The following is a description of a gene set: A general defect of GF K/BxN T cell proliferation response toward antigen motivated us to look for the impairment in GF K/BxN T cells that might leads to the low Ab production and reduced disease phenotype seen in GF K/BxN mice. To find the difference between GF and SPF K/BxN T cells in a broad and non-biased fashion, we performed gene-expression profiling of these cells using microarrays. Genes down-regulated in arthritic (KRN model) CD4 T cells: germ free versus specific pathogen free conditions. Human Gene Set: GSE22140_GERMFREE_VS_SPF_ARTHRITIC_MOUSE_CD4_TCELL_DN studied in species Homo sapiens from publication Wu HJ, Ivanov II, Darce J, Hattori K, Shima T, Umesaki Y, Littman DR, Benoist C, Mathis D (PMID 20620945), and this is the list of marker genes: FAM53B, SYT11, PEX7, SRD5A1, LAMP3, SRGAP2, SLC7A7, BTN3A2, P2RY14, RAB4B, SERPINA1, KIF2A, VAMP5, INPP5D, ACVR1B, SECTM1, PSME2, KIAA0513, GRSF1, TNFAIP2, ENTPD5, SERPING1, IRF4, NFATC3, TAP2, ARHGAP19, CXCL10, SLC6A12, HCP5 (NCBI Gene Id 91955), IDO1, FZD7, TBC1D9, MRTFA, CXCL9, CETN3, PSMB8, TYMP, STOM (NCBI Gene Id 2040), GGH, SAMD4A, GK, VRK2, PNPLA4 (patatin like phospholipase domain containing 4), AARS1, FLOT2, IFI27, LEPROTL1, N4BP2L1, FGL2, FCER1G, RGS3, GPX4, SLC1A5, CDKN1A, TASOR, SH2B2 (SH2B adaptor protein 2), SOCS1, CCR2, ETHE1, CDC42EP2, CHI3L1, TAPBP, SASH1, C1QB, AKR1A1, JAK2, TGFBR2, CIC, CEP250, NDUFV2, HBEGF, HDAC3, C2, BST2, PTK2B, CTSO, TCAF1, PRKAR2B, SPG11, IFITM1, IFI35, HAX1, SCO2, DEAF1, TNRC6B, ANOS1, ARF3, PRKX, ATXN7, ASGR1, TRAFD1, BTN3A3, STAT2, COASY, POLR2H, CCL5, VOPP1 (VOPP1 WW domain binding protein), PADI2, SDHA, CRYBG1, IER2, YARS1, RXYLT1, IGSF6, CUL1, MUC1, GBP1, HLA-DQA1, GBP2, BRD3OS, RBCK1 (RANBP2-type and C3HC4-type zinc finger containing 1), TAP1, PRPF3 (pre-mRNA processing factor 3), PRKY, CSTF3, INSIG2, DOK1, CD38, POLB, ALAS1, DGKZ, LMNB1, SLC20A1, WARS1, COX7A2, PHB2, CKAP5, PLCG2, FZD2, PTPRA, FCHSD2, ST3GAL5, SASH3, HSD11B1, IL10RA, BTN3A1, HCK, CXCL11, WDR7, EXT1 (exostosin glycosyltransferase 1), STAT6, DYNLT1, NDRG1, DNAJC13, FLI1, CLCN4, SELL, NDUFS2, IRF1, NPAT, N4BP2L2, PSMB9, SLC35D2, DECR1, PRPF19, APOL1, EDEM1, TADA3, NDUFV1-DT, RIDA, CSK, VPS9D1, POLR2I, S100A8, PLAAT4 (phospholipase A and acyltransferase 4), TBC1D2B, EZH2, NADK, CEBPA, IL2RG, CASP4, STAT5A, POLR2A, C1S, TRANK1, DDB2, XPNPEP1, RERE, MARS1, PRCP, UBE2L6, HLA-F, SLF2, RPL37, FCGR1A, MR1, PTPN18 (protein tyrosine phosphatase non-receptor type 18), PLEK, PSMA4, CTSC, CTSH (NCBI Gene Id 1512), SIK3, CD55, GGPS1, PSMB10 (NCBI Gene Id 8138), HLA-DQB1, ALDH5A1, ENTPD4, LGALS3BP